The following is a description of a gene set: from publication Darwiche N, Ryscavage A, Perez-Lorenzo R, Wright L, Bae DS, Hennings H, Yuspa SH, Glick AB (PMID 17525749) Genes up-regulated in squamous cell carcinoma (SCC) compared to normal skin. Chemical induction of squamous tumors in the mouse skin induces multiple benign papillomas: high-frequency terminally benign low-risk papillomas and low-frequency high-risk papillomas, the putative precursor lesions to squamous cell carcinoma (SCC). We have compared the gene expression profile of twenty different early low- and high-risk papillomas with normal skin and SCC. Unsupervised clustering of 514 differentially expressed genes (P<0.001) showed that 9/10 high-risk papillomas clustered with SCC, while 1/10 clustered with low-risk papillomas, and this correlated with keratin markers of tumor progression. Prediction analysis for microarrays (PAM) identified genes that distinguished the two papilloma classes, and a majority of these had a similar expression pattern in both high-risk papillomas and SCC. Additional classifier algorithms generated a gene list that correctly classified unknown benign tumors as low- or high-risk concordant with promotion protocol and keratin profiling. Reduced expression of immune function genes characterized the high-risk papillomas and SCC. Immunohistochemistry confirmed reduced T-cell number in high-risk papillomas, suggesting that reduced adaptive immunity defines papillomas that progress to SCC. These results demonstrate that murine premalignant lesions can be segregated into subgroups by gene expression patterns that correlate with risk for malignant conversion, and suggest a paradigm for generating diagnostic biomarkers for human premalignant lesions with unknown individual risk for malignant conversion. species: Mus musculus Human Gene Set: DARWICHE_SQUAMOUS_CELL_CARCINOMA_UP, and this is the list of marker genes: LIF, PDCD5, ACAN, EEF1D, KLK6, PFKL, CAMK4, PTPRCAP, KLF13, LDHA, GSK3B, LYPD2, SUCLG2, CEACAM21, DRD5, CACNA1E, RNASE2, SNHG3, RNF19A, SARAF, SLPI, NCL, SPNS3, STX16, NFE2L2, AXL, FTL (NCBI Gene Id 93315), RPTN, CTSV, SDR9C7, PMEPA1, CHPT1, BZW1, WFDC2, MAN2A2, PPIC (peptidylprolyl isomerase C), TTLL11, SRSF1 (NCBI Gene Id 650453), BAIAP2, GALK1, ELAPOR1, EXT2, SFPQ, H2AZ1, TP73, ENAH, NEK4, JAG1, UBE2C, GSTA1, HSPD1 (heat shock protein family D (Hsp60) member 1), RYR1, CAPN2, MORN5, GPR15LG, CMPK2, CHI3L1, PRG3, CHKA, IL1B, LYZ, IFITM3, HRC, HBE1, NHP2, S100A11, HBS1L, SNHG9, SPP1, ARG1, TMEM248, SPIC, IDE, CCDC38, RASIP1, TRMT1, TCP1, LY6E, DYNLL1, TEKTIP1, SMIM8, HEXA, NCAN, ICAM1 (intercellular adhesion molecule 1), CACYBP, LTBP4, ENO1, ACOT9, GKN3P, GDF5, CITED2, RAB5IF, VHL, CSTA, ENG, CXCL16, RNF181, CLVS1, CDC42EP2, CD248, ID1, PLET1, CHP1, ELAVL1, EEF1B2, YWHAB, COX5B, CCT4 (chaperonin containing TCP1 subunit 4), SOD1, RAB2B, MAP2K5 (NCBI Gene Id 5607), GCLM, FES, POLR1HASP, MT1F, RPS6KA4, RHOH, S100A8, BEST1, UCK2, SOD3, MRPS18A, TMEM65, FABP4, SPRR2A, RUBCN, PDS5B, SAMHD1, ARAP1, RPL39, SUN1, CRELD1, PGK1, SRM, QDPR, TXN, MCAM, BID, S100A9, KLK9, PLAC8, DNAJC1, TGFA, ESD, ARL2, NRSN1, PLEKHA4, FAM162A, PGAM1, LCE3B, CX3CL1